The following is a description of a gene set: species: Homo sapiens Many different molecular mechanisms have been associated with PML-RARalpha-dependent transformation of hematopoietic progenitors. Here, we identified high confidence PML-RARalpha binding sites in an acute promyelocytic leukemia (APL) cell line and in two APL primary blasts. We found colocalization of PML-RARalpha with RXR to the vast majority of these binding regions. Genome-wide epigenetic studies revealed that treatment with pharmacological doses of all-trans retinoic acid induces changes in H3 acetylation, but not H3K27me3, H3K9me3, or DNA methylation at the PML-RARalpha/RXR binding sites or at nearby target genes. Our results suggest that PML-RARalpha/RXR functions as a local chromatin modulator and that specific recruitment of histone deacetylase activities to genes important for hematopoietic differentiation, RAR signaling, and epigenetic control is crucial to its transforming potential. Genes with promoters occupied by PML-RARA fusion protein in acute promyelocytic leukemia(APL) cells NB4 and two APL primary blasts, based on Chip-seq data. Human Gene Set: MARTENS_BOUND_BY_PML_RARA_FUSION from publication Martens JH, Brinkman AB, Simmer F, Francoijs KJ, Nebbioso A, Ferrara F, Altucci L, Stunnenberg HG (PMID 20159609), and this is the list of marker genes: CDK5, LCP2, LTBP3 (NCBI Gene Id 4054), ADGRE2, DAPK2, AJAP1, P2RY2, PITPNM2, ATP8B4, RFX2, PPCDC, RUNX3, BAGE2, GGA1, ZMIZ1, ITGA4, MFN1, MGLL, YTHDF2, TOX2, FAM89B (NCBI Gene Id 23625), ARHGAP30, MIR24-2, FCN1, NPAS4, UACA, ELF4, NMUR1, KPTN, GRK2, RTF2, ARID3B, STRADA, GALC, TMEM41B, GAS7, ENSA, APBB1IP, FRAT1, ITPR2, IRF2BP2, TMEM104, TPR, ARHGEF2, HMGA1, POC1A, ITGB2, CD164, GFOD1, PGPEP1 (pyroglutamyl-peptidase I), IFITM3, DNM2, PEBP4, C11orf21, CDK9, SYT2, RHBDF2, RASGRP2, MRPL34, KLHDC4, LASP1, RNF149, JUND, SQSTM1, UBN2, CETP, DUSP5, MIR23A, NUAK2, TARBP1, KCNAB2, RASA3, NEK6, ABI3, ITPR1, ADAMTS10 (NCBI Gene Id 81794), DNAJB12, WNT9A, SEC11A, RPS19, MMP9, GNB5, RCSD1, MIDN, STXBP2, CYTH4, GPATCH8, GALK2, LBR, ARHGAP45, DOK3, RNF34, CISH, PUM3, KLF13, ELAVL1, PTEN, RARA, SLC9A3, BANF1, RAB43, DDX5, LATS2, PKIG (cAMP-dependent protein kinase inhibitor gamma), LYN, FLNB, H6PD (NCBI Gene Id 9563), SH3BGRL3, ATG16L2, ZZEF1, SMAD3, PXN, NUP85, CCDC88B (NCBI Gene Id 84211), SLC9A1, TNFRSF10B, SKI, DOT1L, TSSK3, RAB37, MX2, SEC11B, DENND3, TYROBP, LMBR1, GALNT6, NFE2, SPG7, OAZ1, CIAO2A, SERPINB1, SMG6, ABHD2, TPRA1, NBR1 (NCBI Gene Id 9740), TK2, TBX6, HCK (NCBI Gene Id 3055), NUDT15, PRKCD, ICAM1, FAAP20, CHST15, DCTN1, PLXND1, ICAM4, PGLS, FBXO46, RAP1GAP2, SIRPA, GSE1, STK24, PSMD9, BANP, UBASH3B (NCBI Gene Id 84959), WDR26, BHLHE40, NADK, SULF2, IQSEC1, TPD52L2, ECE1, SDE2 (NCBI Gene Id 163859), TMEM115, RAB31, MAFB, GRK6, TRNP1, INAVA, NDUFA4, TUBA1C, GLMP, UBL3, RAB11FIP3, HMOX1, SLC35B1, LFNG, LYL1, TMC8, TMCC2, FOSB, MDM1, IZUMO4, TRIM72, BRF1, NINJ1, LAPTM5, SCARB1, UPP1, CSTF1, C5AR1, ODAD1, KMT5A, FNBP1, TNFAIP3, NUP210, RSL24D1, ADORA3, ACP5, RPL9, IDH1, DCTN4, EFHD2, SPTBN1 (NCBI Gene Id 91654), RPS6KA1, SNX20, IRF1, TESC, DCAF11, RSRC2, PKM, ZC3H12A, CXXC5, GNB2, VASP, ANXA11, SH2B1, FCGRT, HIVEP2, SF3A3, PDP2 (pyruvate dehydrogenase phosphatase catalytic subunit 2), ATP2B4, ZNF710, RNF122, PGC (progastricsin), PHF12, CPNE9, RWDD1 (NCBI Gene Id 82733), LETMD1, SH3BP2, PLCG2, MYO9B, ALDH2, MN1, PLCB2, MBP, CUEDC1, MTRF1L, CTCF, MIR663A, MIR29B1, DEF6, CUTA, UCK2, MRPL1, NOLC1, F11R, PGD, ANKRD11, SPI1, TNFAIP2, PTPN6, KLHL24, TUBGCP2, RUNX1, LRRC20, ZNF683, ID1, C15orf39, ADAM8, ATOSB, CCDC174, ZBTB16, SPHK2, IQCD, MIR646HG, SLC7A5P1, ATP6V0C, RAB20 (NCBI Gene Id 55647), PLEKHO1, NLRP3, BABAM2, FOSL2, ZBTB3, TPPP3, NECTIN4, PAFAH2, TIMP2, CHD7, GPR132, ASB2, ALOX5AP, SLC24A3, ARAP1, ACSL1, SPN, UBE2O, TAGLN2, OLIG2, CAMK2G, RUVBL1, KRI1, TRIP4, HECW1, OLIG1, MCAM, SLC25A19, WDR81, CELF2, NIBAN3, PDE4DIP, RAPGEF1, CSK (NCBI Gene Id 1445), HPCAL1, GUSB, ADGRG3, TFDP1, FAM53B, LINC00173, MBD6, LINC02908, NUDT3, FBXL9P, LTB4R, CUX1, PREX1, NUDT9, TARS2, SIK1, LINC00311, EDRF1, CD82, AK1 (adenylate kinase 1), PLEK, SLC22A11, CXCR5, HNRNPM, HDAC4, ZDHHC19, CACNA1C, PTGES, ELL, SUSD3, TSPOAP1, PLEKHA2, NOSIP, MORN3, CTSD, APLP2 (NCBI Gene Id 51680), MAP2K3, LMO2, CRAMP1, AZIN2, SH3PXD2A, PLAC8, NUTF2, TBXAS1, BCL3, NCOR2, PIK3AP1, CDH23 (cadherin related 23), CAPG, NRXN2, TNFRSF4, BLM, KSR1, GTF3A, RPS6KA2 (ribosomal protein S6 kinase A2), AKNA, PMF1, SREBF1, SLC7A10, ACSF3, WNT5B, GBE1, GBA1, FGR, AUH, RAC2, MYO1F (myosin IF), ANP32E, MFSD8, MCM5, PSAP, PIGL, CRTC1, MPG, GRIP2, COTL1, ADGRG5, PSMD3, PEX12, SLC7A5, B3GNT7, PTPRJ, TM9SF4, RPS9, MRPL24, ADCY10, NME1-NME2, RAB3D, RBBP8, TOMM40, EXOSC4, UBE2R2 (NCBI Gene Id 54926), CD58, NECTIN1, FAM216A, YJU2 (YJU2 splicing factor homolog), FXYD6, ZFYVE28, MLXIPL, PIWIL4, KLF2, RPL24, CDS2, DUSP28, CORO2A, FMNL1, MIR223, INHBA, NDRG1, SLC6A6, IFNAR2, SMIM3, IRF8, TOMM20, UPB1, KREMEN1, LINC01565, RAVER1, TMEM143, IRAG1, ZNF595, ANKDD1A, TBP, FGFR1OP2, TYK2, INKA2, HIVEP3, RAB11FIP1, FHOD1, SHISAL2A, SCUBE1, DDIT4, MYH9, GRK5 (G protein-coupled receptor kinase 5), ID2, S1PR3, B4GALT1, ST3GAL2, DRG2, ARID2, ZC3H4, ARRB1, FAM78A, MAML2, RPS6, FLT3, MIR29B2CHG, CCND3, ANKRD33B, STING1, MEF2D, HIP1 (huntingtin interacting protein 1), FERMT3